Given this list of marker genes Il6, Sigirr, Otud4, Il1r2, Il1rn, here is a description of the gene set: Any process that stops, prevents or reduces the frequency, rate or extent of interleukin-1-mediated signaling pathway. studied in species Mus musculus Mouse Gene Set: GOBP_NEGATIVE_REGULATION_OF_INTERLEUKIN_1_MEDIATED_SIGNALING_PATHWAY